Given this list of marker genes BMP4, FZD2, FZD1, HEY2, VANGL2, TGFBR3, here is a description of the gene set: Human Gene Set: GOBP_MUSCULAR_SEPTUM_MORPHOGENESIS The process in which the muscular septum is generated and organized. The muscular septum is the lower part of the ventricular septum. species: Homo sapiens